The following is a description of a gene set: species: Mus musculus Inactivation of CSF3 (G-CSF) signaling Mouse Gene Set: REACTOME_INACTIVATION_OF_CSF3_G_CSF_SIGNALING, and this is the list of marker genes: Socs1, Elob, Uba52rt, Tyk2, Ubb, Uba52, Eloc, Ubc, Ube2d3, Ube2d2a, Ube2d1, Csf3, Rnf7, Lyn, Hck, Socs3, Jak2, Syk, Rps27a